The following is a description of a gene set: Mouse Gene Set: CUI_MIGDC_GM_CSF_RESPONSE_DN studied in species Mus musculus Genes negatively differentially expressed in cell type: MigDC (migratory dendritic cell) upon treatment with cytokine: GM-CSF in mouse lymph nodes in vivo. from publication Cui A, Huang T, Li S, Ma A, Pérez JL, Sander C, Keskin DB, Wu CJ, Fraenkel E, Hacohen N (PMID 38057668) Cytokines mediate cell-cell communication in the immune system and represent important therapeutic targets. A myriad of studies have highlighted their central role in immune function, yet we lack a global view of the cellular responses of each immune cell type to each cytokine. To address this gap, the authors created the Immune Dictionary, a compendium of single-cell transcriptomic profiles of more than 17 immune cell types in response to each of 86 cytokines (>1,400 cytokine-cell type combinations) in mouse lymph nodes in vivo. A cytokine-centric view of the dictionary revealed that most cytokines induce highly cell-type-specific responses. For example, the inflammatory cytokine interleukin-1β induces distinct gene programmes in almost every cell type. A cell-type-centric view of the dictionary identified more than 66 cytokine-driven cellular polarization states across immune cell types, including previously uncharacterized states such as an interleukin-18-induced polyfunctional natural killer cell state., and this is the list of marker genes: Icosl, Tmem123, Slc6a6, Tmem150c, Pnisr, Gadd45b, Kctd12, Xist, Map4k4, Lyst, Mxd1, Mx1, Plxnc1, Trio, Synpo2, Traf1, Slc38a2, Birc2, Arl5c, Il4i1, Apol7c, Tnfaip3, Nav1, Slco5a1, Chka, Pfkfb3, Trps1, Bmp2k, Sat1, Spred1, Flt3, Etv3, Castor2, Il7r, Gtf2a1, Blnk, Ctsh, H2-M2, Ppp4r2, Net1, H2ac25, Parp8, Tmem158, Rcsd1, Creg1, Rasa4, H2-Q7, Dscaml1, Ostf1, Clec2i, Tmcc3, H2-Q6, Arhgap22, Tnfrsf1b, Rptor (regulatory associated protein of MTOR, complex 1), Tspan3, Sned1, Cxcl16, Specc1, Ndnf, Arhgap31, Sec11c, Wnk1, Cdc42ep3, Fosb, Ehf, Phf21a, Ankrd35, Relb, Usp18, Ero1b, Atxn1, Sdhaf1, Fam53b, Tmem176b, Tank